The following is a description of a gene set: species: Homo sapiens mouse primary BMDCs were stimulated with tlr ligands and gene expression changes were profiled on Affymetrix arrays Genes down-regulated in comparison of dendritic cells (DC) stimulated with CpG DNA (TLR9 agonist) at 0.5 h versus those stimulated with CpG DNA (TLR9 agonist) at 8 h. Human Gene Set: GSE17721_0.5H_VS_8H_CPG_BMDC_DN from publication Amit I, Garber M, Chevrier N, Leite AP, Donner Y, Eisenhaure T, Guttman M, Grenier JK, Li W, Zuk O, Schubert LA, Birditt B, Shay T, Goren A, Zhang X, Smith Z, Deering R, McDonald RC, Cabili M, Bernstein BE, Rinn JL, Meissner A, Root DE, Hacohen N, Regev A (PMID 19729616), and this is the list of marker genes: SFT2D1, UBXN2A, UBE2G1, TESK1, PDZD11, TOP1, LMO4 (LIM domain only 4), IFITM2, RMDN3, UBE2E1, RAD17, OSCAR, SASH1, PDGFRB, CHMP4B, CAMSAP1, ZBTB21 (NCBI Gene Id 57487), CLK1, CPTP, MS4A7, LYRM1, COL4A6, SLC6A13, HBP1, CD247, GBP2, LLGL1, DENND5A (NCBI Gene Id 23258), CCR4, BLTP3A, IKBKB, MPC1, ACP2, KRCC1, WARS1, DNAJA1, PSMA6, SRA1, MOB4, RPE, ABCB1, MTHFS, FMR1, IFNB1, PILRA, ARL6IP6, GHITM (NCBI Gene Id 27069), TOR1AIP1, PRKCE, TNFSF8, ARL14EP, TBC1D1, PSMB9, ASAH2, C18orf32 (chromosome 18 open reading frame 32), WASHC4, ANXA1, SERINC1, SRGAP2, DSCAML1, ILF3, PCMT1, TBC1D15, PTK2B, CHI3L1, CHM (NCBI Gene Id 158677), VPS54, TFG, PHC2, ASB13, NOS2, CLIC4, FAM53C, TBC1D13, HSPB2, IFIT1B, PITPNB, ENO2, HEATR6, TAP1, INTS4, MOCS2, ELK3, AGRN, DUSP16, MKKS, DRAM2, SLAMF7, CLIP1, OAS1, CCNG2, ATOSB, DENND1B (DENN domain containing 1B), SERPINC1, LAP3, TRIM34, TBX18, RAB10, ASF1A, SLC38A2, ME1, CCL5, FCGR3A, CTU1, TENT2, PRPF38A, IDI1, ORM1, CCL2, HOOK2, SNX20, DGCR8, PSMD10, PALS1, CRLF3, ZEB1, ZNF281, SMIM7, PSMD12, SUOX, ATP6V1E1, WDFY1, IL15, AK4, EYA3, STXBP1, CREB1, ARAP2, CHRNA5, ABCA1, THEMIS2, GRHL1, TNPO2, SERPINE1, TM9SF4, NUP54, CXCL11, PHOSPHO2, RTP4, IGF2BP2, TREM1, MTPN, SLC31A1, TMEFF1, UFD1, MBD2, AKNA, KRIT1, TTC1, EIF1AY, RGS14, F11R, FAM3B, USP53, VEGFC, DPF2, RNPC3, RBM7, TLK2, DYNC1I2, TNFAIP2, POU2F2, ENPP4, SLC22A5, MTF2, THBS4 (thrombospondin 4), TRA2A, HLA-E, LYPLA1, DNAJC1, RSRP1, BCKDHB, PARP14, NIBAN1, PLAAT3, SLC7A8, SOS2, BRD2, NFXL1, CAV1, CASP1, FAM8A1, KCTD14, PNPT1, ANKRD24, PPP2R3C, BATF2, USP18, COX18, SIKE1, EPHA4, ICAM1, KPNA4, CRIPT, CCL7, REL, RDH11, GFPT1, FAM20B